The following is a description of a gene set: studied in species Mus musculus Mouse Gene Set: GOBP_POSITIVE_REGULATION_OF_G_PROTEIN_COUPLED_RECEPTOR_SIGNALING_PATHWAY Any process that activates or increases the frequency, rate or extent of G protein-coupled receptor signaling pathway activity., and this is the list of marker genes: Arrb2 (NCBI Gene Id 216869), Slc39a14, Edn1, Tmod2 (NCBI Gene Id 50876), Ece1, Hif1a, Gsk3a, Prmt5, Cav2, Mrap2, Prkca, Nos1, Grp, Gas2l2, Fgf8, Pde5a, App, Gpr27, Lrrk2, Adrb1, Trem2, Phb1, C3, Drd2, Gper1, Klk5, Chga, Acp3, Myh9, Itgb3, Ptgdr2, Pde6h, Mrap, Ccl5, F2, Drd3, Necab2, Cntn2, Vps35, Pde6g, Pomc, Klk14, Klk6